Given this list of marker genes KIF1B, GIMAP6, YARS2, STK38, TMIE, here is a description of the gene set: from publication Gavin MA, Rasmussen JP, Fontenot JD, Vasta V, Manganiello VC, Beavo JA, Rudensky AY (PMID 17220874) Human Gene Set: GAVIN_IL2_RESPONSIVE_FOXP3_TARGETS_DN FOXP3 target genes down-regulated in T lymphocytes after stimulation with IL2. Regulatory CD4+ T cells (Tr cells), the development of which is critically dependent on X-linked transcription factor Foxp3 (forkhead box P3), prevent self-destructive immune responses. Despite its important role, molecular and functional features conferred by Foxp3 to Tr precursor cells remain unknown. It has been suggested that Foxp3 expression is required for both survival of Tr precursors as well as their inability to produce interleukin (IL)-2 and independently proliferate after T-cell-receptor engagement, raising the possibility that such 'anergy' and Tr suppressive capacity are intimately linked. Here we show, by dissociating Foxp3-dependent features from those induced by the signals preceding and promoting its expression in mice, that the latter signals include several functional and transcriptional hallmarks of Tr cells. Although its function is required for Tr cell suppressor activity, Foxp3 to a large extent amplifies and fixes pre-established molecular features of Tr cells, including anergy and dependence on paracrine IL-2. Furthermore, Foxp3 solidifies Tr cell lineage stability through modification of cell surface and signalling molecules, resulting in adaptation to the signals required to induce and maintain Tr cells. This adaptation includes Foxp3-dependent repression of cyclic nucleotide phosphodiesterase 3B, affecting genes responsible for Tr cell homeostasis. species: Mus musculus